The following is a description of a gene set: Genes up-regulated during primary acute viral infection: B lymphocytes versus CD8 T cells. Murine Cytomegalovirus (MCMV) infection leads to early activation of various immune cells, including B and T lymphocytes, before the actual initiation of antigen-specific adaptive immunity. This activation is partly driven by innate cytokines, including type I interferon (IFN), which are induced early after infection. The objective of this study was to address the role of type I IFN in shaping early/innate B and T cell responses to a primary acute viral infection. In order to decipher the specific impact of IFN-I on cell subsets, we performed a genome-wide expression analysis on WT splenic B and CD8 T lymphocytes isolated from C57BL/6 mixed bone marrow chimera mice. This study complements series GSE39555, which focused on early responses of NK cells and of the two subsets of conventional dendritic cells. species: Homo sapiens Human Gene Set: GSE45365_HEALTHY_VS_MCMV_INFECTION_BCELL_IFNAR_KO_UP, and this is the list of marker genes: FAM133B, TNFRSF9, DBI, NCAPH, EHD3, FSCN1, SNAI2, ACTR3, LANCL2, NEDD4L, GMFB, HJURP (Holliday junction recognition protein), DHRS2, NAPRT, MED6, FOXK1, ZNF142, CUL3, IGFBP3, PGR, IDH1, PYGL, ZFYVE26, CNOT6, RFC2, TLK1, RACK1, BABAM1, POLR1B, FAM117B, RIF1, L2HGDH, ERCC3, APBA3, PSMD1, SEPTIN2 (septin 2), PML, TMEM237, CDKN2B, AURKA, CDK6, MAX, JUN, RAB15, NCOR1, ORC2, MAPK1IP1L, BTBD7, KIF14, METTL3, TAX1BP1, GPD2, PSMB7 (NCBI Gene Id 5695), PIGH, MZT2B, CCND1, GPHN, AKR1C1, EDNRB, NFE2L2, KIF4A, PKP4, AREL1, INO80D, PLPPR1, GNG11, SLIRP, TUSC2, TMBIM4, CYCS, TOP1, DNER, SEPTIN7, LYSET, CXCR4, TSN, ATL1, TCEAL4, FOXG1, NCL, ZNF839, ATG14, SPC24 (SPC24 component of NDC80 kinetochore complex), TAB1, FARSB, CYB5D1, INPP1, ORMDL1, LYPD1, ANKIB1, APOBEC3B, BLMH, SKAP2, PPM1A (NCBI Gene Id 5494), EIF2AK1, TTC5, IGF2BP3 (NCBI Gene Id 10643), MFF, RETREG2, PTPN21, NXN, TMEM243, SAMD5, DUSP1, KIF20A, PSMD8, ENSA (NCBI Gene Id 51620), CHURC1, TPX2, PTGER2, APPBP2, NDUFA12, SULT1C4, ZBTB4, THOC5, TMEM200A, TIGD1, RAB3GAP1, BUB1B, SAMD9, PSMC1, NEFL, GMPPA, FOXN3, PPP1R7, PPIA, HECTD1, RALB, PIKFYVE, EIF2B2, PSMC5, SGO2, IFITM2, BIN1, PSMA3-AS1, SOCS2, BIRC5, KIF2C, PLEKHA5, GHR, PTCHD1, PRRX1, RTN1, SCRN1, WDSUB1, IL1RL2, MDH2, FZD1, MARCHF7, EMP3, MSL1, ZBTB2, PIAS1 (NCBI Gene Id 8695), TRIP12, TMEM60, SOX9, BCS1L, EIF4G3, PLPPR4, MIS18BP1, MARK3, MT1F, GLI3, IER3, KDM3A, RNF216, BMP2, TUSC1, EPAS1 (endothelial PAS domain protein 1), GCC2, PSME4, UBE2QL1, BUD23, FGF13, ANLN, EEF1B2, WDR36, STAT1, NRDE2, DLGAP5, EIF2S1, ZC3H8, DMRTA1, COX16, MTHFD1, POLR2D, COL5A2, PAX3, BAZ2B, EIF3G, EEF1D, PCDH20, RPL6, FIGN, HSPD1, SNW1, CLASP1, GCNA (NCBI Gene Id 93953), USP40, NEK2